Given this list of marker genes GALNT3, SLC12A1, PHEX, PLEKHM1, CDKN1A, RET, YY1, KCNJ10, ZFX, CDKN2B, CDKN2C, SLC26A4, ANKH, OCRL, CA2, KDM1A, CDKN1B, GNAS, CDC73, AP2S1, SLC4A2, MEN1, TRPV6, CASR, CYP27B1, CYP2R1, ACTG2, ARMC5, FOXI1, GCM2, GNA11, VDR, CLDN10, here is a description of the gene set: Excessive production of parathyroid hormone (PTH) by the parathyroid glands. Hyperparathyroidism Human Gene Set: HP_HYPERPARATHYROIDISM species: Homo sapiens